The following is a description of a gene set: studied in species Mus musculus Mouse Gene Set: GOBP_POSITIVE_REGULATION_OF_OXIDATIVE_STRESS_INDUCED_INTRINSIC_APOPTOTIC_SIGNALING_PATHWAY Any process that activates or increases the frequency, rate or extent of an oxidative stress-induced intrinsic apoptotic signaling pathway., and this is the list of marker genes: Sfpq, Vnn1, Mmp2, Mcl1, Adcy10, Nox1 (NCBI Gene Id 278150), Fbxw7, Sod1, Park7